The following is a description of a gene set: The application of human embryonic stem (ES) cells in medicine and biology has an inherent reliance on understanding the starting cell population. Human ES cells differ from mouse ES cells and the specific embryonic origin of both cell types is unclear. Previous work suggested that mouse ES cells could only be obtained from the embryo before implantation in the uterus. Here we show that cell lines can be derived from the epiblast, a tissue of the post-implantation embryo that generates the embryo proper. These cells, which we refer to as EpiSCs (post-implantation epiblast-derived stem cells), express transcription factors known to regulate pluripotency, maintain their genomic integrity, and robustly differentiate into the major somatic cell types as well as primordial germ cells. The EpiSC lines are distinct from mouse ES cells in their epigenetic state and the signals controlling their differentiation. Furthermore, EpiSC and human ES cells share patterns of gene expression and signalling responses that normally function in the epiblast. These results show that epiblast cells can be maintained as stable cell lines and interrogated to understand how pluripotent cells generate distinct fates during early development. from publication Tesar PJ, Chenoweth JG, Brook FA, Davies TJ, Evans EP, Mack DL, Gardner RL, McKay RD (PMID 17597760) studied in species Mus musculus Human Gene Set: TESAR_ALK_AND_JAK_TARGETS_MOUSE_ES_D4_DN Genes down-regulated in mES cells (mouse embryonic stem cells) after tratment with the ALK inhibitor SB-431542 and JAK inhibitor I., and this is the list of marker genes: NODAL, LEFTY1, CRIPTO, NANOG, POU5F1, LEFTY2